The following is a description of a gene set: Reactome Pathway: Hedgehog ligand biogenesis part of: Signaling by Hedgehog Mammalian genomes encode three Hedgehog ligands, Sonic Hedgehog (SHH), Indian Hedgehog (IHH) and Desert Hedgehog (DHH). These secreted morphogens can remain associated with lipid rafts on the surface of the secreting cell and affect developmental processes in adjacent cells. Alternatively, they can be released by proteolysis or packaging into vesicles or lipoprotein particles and dispersed to act on distant cells. SHH activity is required for organization of the limb bud, notochord and neural plate, IHH regulates bone and cartilage development and is partially redundant with SHH, and DHH contributes to germ cell development in the testis and formation of the peripheral nerve sheath. <br><br>Despite divergent biological roles, all Hh ligands are subject to proteolytic processing and lipid modification during transit to the surface of the secreting cell. Precursor Hh undergoes autoproteolytic cleavage mediated by the C-terminal region to yield an amino-terminal peptide Hh-Np (also referred to as Hh-N). No other well defined role for the C-terminal region of Hh has been identified, and the secreted Hh-Np is responsible for all Hh signaling activity. Hh-Np is modified with cholesterol and palmitic acid during transit through the secretory system, and both modifications contribute to the activity of the ligand. <br><br>At the cell surface, Hh-Np remains associated with the secreting cell membrane by virtue of its lipid modifications, which promote clustering of Hh-Np into lipid rafts. Long range dispersal of Hh-Np depends on the untethering of the ligand from the membrane through a variety of mechanisms. These include release of monomers through the combined activity of the transmembrane protein Dispatched (DISP2) and the secreted protein SCUBE2, assembly into soluble multimers or apolipoprotein particles or release on the surface of exovesicles. species: Homo sapiens, and this is the list of marker genes: SHH, PSMA7, VCP, GPC5, PSMD11, SYVN1, PSMC5, PSMA6, UBA52, PSMD13, PSMD2 (proteasome 26S subunit ubiquitin receptor, non-ATPase 2), PSMC4, SEL1L, PSMB3, DERL2, ADRM1, DISP2, HHAT, PSMD7 (NCBI Gene Id 5713), PSMB5, IHH, PSMA5, NOTUM, PSMC6, PSMB6, RPS27A, SEM1, UBC, SCUBE2 (signal peptide, CUB domain and EGF like domain containing 2), PSMA3, P4HB, PSMD6, PSMA1, UBB, PSMB1, PSMC2, PSMB4, PSMB7, PSMD1, PSMC1, DHH, PSMD8, PSMD14, ERLEC1, PSMC3, PSMD12, PSMB2, PSMA4, ADAM17, OS9, PSMD3, PSMA2